Given this list of marker genes ALAS2, EGLN1, AQP11, SOD2, HIF1A, CIAO3, NNT, WNT7B, here is a description of the gene set: A homeostatic process involved in the maintenance of a steady state level of oxygen within a cell. Human Gene Set: GOBP_INTRACELLULAR_OXYGEN_HOMEOSTASIS species: Homo sapiens